The following is a description of a gene set: Mouse Gene Set: GOBP_OUTER_MITOCHONDRIAL_MEMBRANE_ORGANIZATION A process that is carried out at the cellular level which results in the assembly, arrangement of constituent parts, or disassembly of the mitochondrial outer membrane. studied in species Mus musculus, and this is the list of marker genes: Bax, Hspa4, Pdcd5, Hsp90aa1, Mtch1, Mtch2, Samm50, Tomm22, Pdcd5-ps